Given this list of marker genes Plat, Vwf, F7, Plau, Serpinb2, F8, Plg, F12 (coagulation factor XII (Hageman factor)), Serpine1, F13b, Serpinf2, F11, F9, Fgg, F5, F2, F10, F8a, Fga, Fgb, here is a description of the gene set: Blood clotting cascade studied in species Mus musculus Mouse Gene Set: WP_BLOOD_CLOTTING_CASCADE